Given this list of marker genes MTR, MTHFR, AHCYL2, MTRR, DNMT3A, MAT1A, AHCY, DNMT3B, MAT2B, MTHFD1, DNMT1, SHMT1, here is a description of the gene set: Human Gene Set: WP_SPINA_BIFIDA studied in species Homo sapiens Spina bifida